Given this list of marker genes SLC2A10, CANT1, CREBBP, COL1A1, HSPG2, IFT172, SBDS, CPLX1, BGN, DUOX2, IHH (Indian hedgehog signaling molecule), GNPAT, PRKAR1A, SMARCAL1, NPR2, COL1A2, ADAMTS2, PIK3C2A, RET, GDF5 (NCBI Gene Id 8200), DVL1, PCNT, FGFRL1, IFT52, DUOXA2, SRP54, SIL1, BMP4, KIAA0586, ADAMTSL2, SALL1, RUNX2, DLK1, AIFM1, CDC6, GLB1, LHX3, RAD21, SRCAP, MIA3, BPNT2, DYM, TBX4, MATN3, POU1F1, EP300, PDE4D, SKIC3, TRIP11 (thyroid hormone receptor interactor 11), HESX1, IYD, TRAPPC2, COG1, MRPS28, COL9A1, MGP, RTL1, SLC39A13, MIR140, TREX1, COL2A1, PLOD3, NPR3, COMP, TINF2, BRF1, DNAJC21, FLNA, WNT5A, TBC1D2B, TSHR, CCN6, TPO, SLC5A5, EXTL3, TSHB, RAB23, HS2ST1, UNC45A, CSPP1, FZD2, CTBP1, ERI1, RSPRY1, ATR, POR, EIF2AK3 (eukaryotic translation initiation factor 2 alpha kinase 3), UFSP2, NEK9, RAB3GAP2, NKX3-2, ERCC8, IFT140, RPL13, COL11A2, PEX5, EVC, NEK1 (NCBI Gene Id 51037), LETM1, KCNH1, GNPTG (N-acetylglucosamine-1-phosphate transferase subunit gamma), LHX4, RNU4ATAC, FLNB, BMPR1B, COL9A2, ATP7A, ARSL, TRPS1, MEG3, RINT1, COL10A1, COG4, NSD2, KIF22, COL11A1, EXT1, PROP1, RMRP, B3GALT6, EFL1, CHST3, ACAN, IFIH1, GPX4 (NCBI Gene Id 2879), ERCC6, FN1, TONSL, TRPV4, EVC2, TG, KIF15, DVL3, COL9A3, RPS6KA3, FGFR3, SLC26A2, here is a description of the gene set: An anomaly of one or more epiphyses of a limb. Human Gene Set: HP_ABNORMAL_LIMB_EPIPHYSIS_MORPHOLOGY Abnormal limb epiphysis morphology species: Homo sapiens